The following is a description of a gene set: Genes predicted to be targets of miRBase v22 microRNA hsa-miR-6791-5p in miRDB v6.0 with MirTarget v4 prediction scores > 80 (high confidence targets). species: Homo sapiens from publication Chen Y, Wang X (PMID 31504780) Human Gene Set: MIR6791_5P, and this is the list of marker genes: TMEM35A, PI4KB, ARHGAP18, NOS1, TMEM164, B4GALT1, C19orf73, SHISA7, P2RY2, ARHGAP36, OSBPL3, CRTC1, ATXN7L3, EPOP, GARRE1, HSPB7, KMT5C, CAPN15, RNF19B, CBX7, PPM1F, SHISAL1, IL1RAP, PLEC, UBE2Z, CALN1, CARMIL3, USH2A, PTPN9, DDX6 (NCBI Gene Id 1656), GYPC, SH3PXD2B, CLIP3, MDGA1, XYLT1, WNT4, FBXO41, PDCD4, DYRK2, NBL1, IQSEC3, CAMK2A, TANC2, MKRN1, NFYC, WNT6, VASH1, CLCF1, STAT2, MAPRE3, UBASH3B, NALF2, ZFAND3, SDC3, ERGIC1, SH3BGRL2, PRH2, UNC5A, C1orf167, TSPAN18, POU3F2, MLLT1, SLC26A9, CDR2L, KCNE4, RNF220, ZNF862 (NCBI Gene Id 648125), MLEC, OSR2, NCAM1, ZBTB34, DOK2, CMKLR1, MOSPD3, RGMA, CCDC102A, STXBP5, TLCD2, NECTIN1, SPRY3, RLF, PHF21A, STYK1, DAGLA (NCBI Gene Id 747), WAPL, ZNF395, BCL2L2-PABPN1, TTC39C, ORAI3, WFIKKN2, RIMS4, GATAD2B, CDCA3, RNPEPL1, TBX15, FIBCD1, CDC25A, TBC1D16, GARS1, ITGB1, PPP3CB, C4orf19, C1QTNF6, HIP1, WDR47, CIMAP3 (ciliary microtubule associated protein 3), PLK3, TNPO1, LDB1, CPSF7, ZNF322, RRP36, CPLX2, METTL1, APBA1, ADAR, ELFN2, ZBTB40, IQCG, MTCL2 (microtubule crosslinking factor 2), SLIT2, GPSM1, DCAF7, PDGFRB, TBC1D2, NINJ1, DESI1, GALNT16, MGA (MAX dimerization protein MGA), PHF24, FOSL2, INPP5F, LMOD1, IGLON5, LHX9, ST8SIA2, CPNE5, TACC2, TRIM10 (NCBI Gene Id 95309), TPBGL, AP1M1, NCDN, HDAC7, CASTOR2, PABPN1, CLEC14A, ZNF362, CWC25, RNF44, SPEN, KY, AAK1, CDC42BPG, MAP3K14, RALGPS1, RCE1, BBS1 (NCBI Gene Id 79702), IRF1, MYOCD, PIK3CA, FBXL19, ZNF335, MIEF2, FMNL3, EPB41L4A, TMEM229B, FAM234A, RHOBTB1, TMEM8B, SLC45A4